Given this list of marker genes DCK, DGUOK, AK5, GUK1, ADK, here is a description of the gene set: studied in species Homo sapiens Human Gene Set: GOBP_PURINE_DEOXYRIBONUCLEOTIDE_BIOSYNTHETIC_PROCESS The chemical reactions and pathways resulting in the formation of purine deoxyribonucleotide, a compound consisting of deoxyribonucleoside (a purine base linked to a deoxyribose sugar) esterified with a phosphate group at either the 3' or 5'-hydroxyl group of the sugar.